The following is a description of a gene set: species: Mus musculus Mouse Gene Set: REACTOME_INTRAFLAGELLAR_TRANSPORT Intraflagellar transport, and this is the list of marker genes: Ift43, Ift80 (intraflagellar transport 80), Ift27, Kif3b, Tuba4a, Dynlt2b, Ift46, Dynlt5, Tuba3a, Dynll2, Ift172, Ift70b, Dynll1 (dynein light chain LC8-type 1), Tnpo1, Ift122, Ift140, Tuba1c, Ift70a2, Dync2li1, Tuba1a, Kif3c, Traf3ip1, Dync2i2, Ift81, Ift20, Tubb2b, Dynlt2a1, Dynlrb1, Tuba3b (NCBI Gene Id 22147), Tubb3, Ift74, Tubb4b, Kifap3, Trip11 (thyroid hormone receptor interactor 11), Tubb2a, Tubb1, Dynlt2a3, Cluap1, Dynlrb2, Kif3a, Dync2h1, Ift52, Dync2i1 (NCBI Gene Id 217935), Ift57, Tubb6, Ift25, Ttc21b, Tubb4a, Ift56, Kif17, Ift70a1, Wdr35, Tuba1b, Ift22, Wdr19